Given this list of marker genes KCNJ4, CRYBA4, KXD1, RPL22, KCNN1, IGFBP3, RHCG, FXYD7, ZNF841, LRRC17, RPL7, GAPDHS, PMS2 (NCBI Gene Id 91271), TATDN2, POM121L2, RPL19, RAC3, WNT11, GPR88, PDILT, BFSP1, ERBIN, GAL (galanin and GMAP prepropeptide), IKZF1 (NCBI Gene Id 55429), MYH6, PCDHAC1, PTPRC, SLC12A1, ACTL10, APOC4, CTRC, C19orf73, RPL5, GUCA2A, CORO1A, SARAF, LRP6, INSYN1, MYLIP, SPACA4, TNNC1, GRAP2, RPS16, DMRTC1B, LRRC4, CPSF4L, RPS3A, GGT7, COX6A1, TAGLN3, RPS4X, LGI3, MICAL2, RPL13A, SLC9A3, HSPB2, EIF3F, MDH1B, C2CD4B, TSPAN11, PHF20L1, RPL6, COX7A2, C20orf96, ATP5MC3, NRF1, SPRR2F, CAV3, C17orf99 (chromosome 17 open reading frame 99), SLC23A3, CDC37L1, TPT1, RPL26, NGFR, RIMKLB, TTR (transthyretin, NCBI Gene Id 7276), CNIH3, ZDHHC11, ELF4, OXTR, SLC39A2, PCP4, SEPTIN12, KRT78, ALOX15, TRAM1, MED1, PRRC2C (proline rich coiled-coil 2C), TUB, PABPC1, NAA11, KMT2A, DENND1C, PRDM8, BIRC6 (baculoviral IAP repeat containing 6), STEAP3, ASPHD1, RPS7, COX6B1, STK36, SFTPB, FAM170B, SSUH2, PKLR, BARX1, SLC28A2, SNCB, CEMIP, COX5A (cytochrome c oxidase subunit 5A), TMEM63C, RPS10, RPS6, BRINP2, TOGARAM2, SYCE1L, TMEM91, SLC6A14, KRT4 (NCBI Gene Id 3851), SIGLEC7, UNC13C, HCG4, PRIMA1, LMF2, ERN2, ZNF292, RPL18, CCDC167, FNDC8, RPS6KL1, FXYD4, GLIS1, ROCK1, P2RX6, TEKT5, LYZL4, RPS23, C16orf95, RPS25, RPL27A, SGCD, HERC1, ACTB, GAS7, TGM5, RPL17, NLRP4, TGM6, CSTA, MOK, SH2B2, HTR6, MORN1, GZMM (NCBI Gene Id 3004), CPLX4, IL5RA, RGS8, SLC16A3, SSTR3, MYH14, CSPG4, KSR1, UBR4, ARMC9, BCLAF1, PLXNB3, SLC5A1, RPL28, RPS14, MISP, MYCT1, CREBBP, ARAP2, FBXL7, PRAMEF12, BSND, SGMS2, UPF2, DQX1, CDH18, RPL9, UPK3A, FGB, KCNK10, SNORC, ATOH7, TNRC6B, SLC7A13, AGXT, ITGA4, STX1B, ACSM5, IL4, SVOP, MET, COX4I1, BTG1, HOXD8, here is a description of the gene set: treatment of mesenteric lymph nodes with soluble lymphotoxin-beta receptor for 0,1,2,3,27 and 35 days species: Homo sapiens Genes up-regulated in mesenteric lymph nodes: control versus 1 day after injection with soluble form of LTB. from publication Huber C, Thielen C, Seeger H, Schwarz P, Montrasio F, Wilson MR, Heinen E, Fu YX, Miele G, Aguzzi A (PMID 15843551) Human Gene Set: GSE2124_CTRL_VS_LYMPHOTOXIN_BETA_TREATED_MLN_UP